The following is a description of a gene set: from publication Hutcheson J, Scatizzi JC, Siddiqui AM, Haines GK 3rd, Wu T, Li QZ, Davis LS, Mohan C, Perlman H (PMID 18275831) Human Gene Set: GSE10325_BCELL_VS_LUPUS_BCELL_DN Genes down-regulated in comparison of healthy B cells versus systemic lupus erythematosus B cells. Gene expression profile studies have identified an interferon signature in whole blood or mononuclear cell samples from patients with systemic lupus erythematosus. This study was designed to determine whether specific lymphocyte and myeloid subsets freshly isolated from the blood of systemic lupus erythematosus patients demonstrated unique gene expression profiles compared to subsets isolated from healthy controls. species: Homo sapiens, and this is the list of marker genes: BLMH, HLA-A, AICDA, SEC11A, PSME1, EIF2AK2, SH3GLB1, CLEC2B, PIGK, GLRX, USP18, OAS3, IFIT3, RAPGEF2, CANX, UBE2L6, KLF10 (NCBI Gene Id 7071), HMMR, SRP72, CTSC, MRPL42, ACTMAP, LAMP2, ACSL4, SUZ12, NAGA, GRAMD2B, APOL3, ATF7IP, DNAJC3, ADAR, NCOA6, NDUFA4, CALU, SEC24A, SRP19, CEP55, MX1, GFPT1, PLSCR1, WSB2, NMI, PGAM1, OASL, KIF11, ITCH, CYCS, PSMB9, GGH, HLA-E, KPNA3, HERC5, MRPS14, MAST1, IFI44L, ASB7, PSMA5, MOXD1, GBP1, DLGAP5, RHOB, TIPARP, VAMP5, UBE2L3, MAN1A1, TBX21, SDC1, SAT1, APOBEC3G (NCBI Gene Id 80065), TOP1, SPATS2L, IGLV4-60, CD38, ZMIZ1, PSME2, CHST11, BCAR3 (BCAR3 adaptor protein, NSP family member), INPP1, APOBEC3A, IFIT1, YARS1, DDX60, RTP4, MICB, IFI6, BCL2L11, MGAT2, SRGN, PJA2, POMP, IRF7, LAP3, TMPO, TRAM1, DPM1, NAMPT, CDS2, DHRS9, BUD31, DYNLT1, ERH, SLC25A46, FAS, IER3IP1, PSMA6, BLVRA, OAS2, FNDC3B, SLC7A5 (NCBI Gene Id 8140), XAF1, GLG1, PRKCI, ASCC1, REC8, CDCA8, IL12A, SCO2, NKG7, ATOX1, AP5S1, TAP1, TMED5, STAT1, PDIA5, CFLAR, VRK2, MINAR1, ZWILCH, ETFB, TMEM248, TMEM258, RGS13 (NCBI Gene Id 6003), IFITM1, TRAPPC2L, TXNRD1, IFI35, WARS1, ATG3, EAF2, NEU1, MAGT1, SLAMF1, ATP5MF, ANP32E, TAS2R13, RALA, RAB6A, RAB27A, SRSF9, CCR2, CHST12, CCR1, TRABD, EHD4, SLC43A3, THEMIS2, HMGN3, CAV1, SLC31A2, ISG20, TMEM140, MYL6B, LGALS3, RBM47, IDH2, OPTN, DUSP5, APOL1, IFI44, GOLPH3 (NCBI Gene Id 64083), RGS1, CTBS, HERC6, SPATS2, MAN1A2, ISG15, SLC25A40, TMEM30A, COA4, CDC42, PIGP, KDELR2, IFI27, THOC7, PIPOX, ATP5ME, RSAD2, ELL2, SLFN12, COX5A, PRPF40A, DDOST, GPR137B, VAPA, KYAT3, BID, C12orf43, PPIF, LRP8, BTG3